The following is a description of a gene set: An abnormally increased degree of bleeding following a superficial injury to the surface of the skin. Excessive bleeding from superficial cuts Human Gene Set: HP_EXCESSIVE_BLEEDING_FROM_SUPERFICIAL_CUTS species: Homo sapiens, and this is the list of marker genes: F2, ITGA2B, TPM4, BLOC1S3, EPHB2